The following is a description of a gene set: Human Gene Set: GOBP_SYNCYTIUM_FORMATION studied in species Homo sapiens The formation of a syncytium, a mass of cytoplasm containing several nuclei enclosed within a single plasma membrane. Syncytia are normally derived from single cells that fuse or fail to complete cell division., and this is the list of marker genes: ADAMTS15, NPHS1, CYP19A1 (cytochrome P450 family 19 subfamily A member 1), EHD1, RIPOR2 (RHO family interacting cell polarization regulator 2), OCSTAMP, DOCK2, DCSTAMP, IZUMO1, ERVFRD-1, RAPGEF3, MAPK14, ENSG00000233887, TCTA, GDF15, TYROBP, DOCK1, CD81, WNT1, MYOD1, CACNA1H, MYH9, NFATC2, IL4R, CD9, DOCK5, NEO1, ERVW-1, ADGRB3, TNFSF14, NOS1, FLOT1, CXCL9, TREM2, ERCC1 (ERCC excision repair 1, endonuclease non-catalytic subunit), CD109, SBNO2, SCGB3A1, CDON, CAV3, KCNH1, EHD2, DYRK1B, MIR515-1, ADAM9, ITGB1, ERVH48-1, GCM1, CXCL10, MYMK, ADGRB1, CACNA1S, CD53, SH3PXD2A, PLEKHO1, TMEM182, MYOG, ADAM12 (ADAM metallopeptidase domain 12), CCL8, ADAMTS5, CAMK1, TANC1, CFLAR (NCBI Gene Id 8837), MYMX, PTGFRN, CAPN2, VASH2